The following is a description of a gene set: Mouse Gene Set: GOBP_PROTEIN_O_LINKED_GLYCOSYLATION_VIA_THREONINE The glycosylation of protein via the O3 atom of peptidyl-threonine, forming O3-glycosyl-L-threonine; the most common forms are N-acetylgalactosaminyl, mannosyl, and galactosyl threonine. studied in species Mus musculus, and this is the list of marker genes: Eogt, Galnt2, Galnt16, Galnt1, Galnt4, Galntl6, Galnt11, Galnt13, Galnt6, Galnt3